Given this list of marker genes EMP1, CEBPB, RBM48, RNF19A, SLC25A30 (solute carrier family 25 member 30), BCL2L11, MALT1, ARF6, NFKBIZ, UTP23, FAM133B, NSMCE1, GUCD1, ZFP1, TNFRSF1B, MAGOHB, IGFBP4, SELP, GBP6, SSH2, SPECC1 (sperm antigen with calponin homology and coiled-coil domains 1), KBTBD8, SCO1, MLLT3, KLHDC2, FAS, FRMD6, FFAR2 (NCBI Gene Id 2867), TIGD2, CEBPD, CASP4, RNF31, RNF149 (NCBI Gene Id 284996), BLTP3B, ABHD17C, MTMR3, ASB2, TIRAP, ZBP1, SYNJ1, IFITM3, STAT3 (NCBI Gene Id 6774), C21orf91, PPP1R16B, MDFIC, SLC41A1, TGM2, ELOVL6, PTPN1, FOSL2, GPR155, LGALS3BP, GPLD1, OSM, PUS7L, NAA16, PPP2CB, ZNF281, RRAS2, RAB27A, TXNRD1, ARAP2, PPAN, SLC2A1, IRGM, SLFN13, NOTCH1, KBTBD11, PCGF5, PRDM1, PDE12, SEMA4D, TCP11L2, GZMB, GNA13, BHLHE40, NFE2L2, SERPINB1, FURIN, SLC39A1, NSD3, ST3GAL4, KSR1, STAT1, SMAD5, TIPARP, RASGRP1, NABP1, BMP2K, TAF5 (TATA-box binding protein associated factor 5), FRMD4B, RTP4, FAM241A, G3BP2, CDKN2D, PPRC1, MAPK6, SLC38A2, SAMSN1, SGK1, PGS1 (phosphatidylglycerophosphate synthase 1), AHR, JAK2, ARMCX6, ARL5A, AOPEP, CRYBG1, IRF9, ZSCAN12, ADORA2B, EGLN3, CSRNP1, PPA1, IL24, PLSCR1, HIF1A, SLC35F5, MXD1, ADAM19, ODC1, DTX3L, TBX21, RRAGD, MAPKAPK2, TNFRSF25, NFIL3, STX11, XAF1, PRNP, ZFPM1, KAT2B, IKZF4, HLX, KRI1, MFSD6, YIPF6, CIRBP, MIDN, EPAS1, TREML2, ABI3, MAP3K8, RAPGEF6, ASF1A, IFI35, LTA, ARMCX3, CHD7, BIRC3, TRIM25, IL6ST, SEC24A, DIS3, IRF7, CGAS, TMEM64, ADPRM, LIF, APEX1, WDR44, AQP9, GJA1, FLOT1 (flotillin 1), CSF1, VPS54, ABHD17B, CD82, SGMS1, GATA1, TWF1, PICALM, RUNX3, XBP1, TNFAIP8, PARP14, PROS1 (NCBI Gene Id 5627), SLC30A4, SLC49A4, PTGER4, UBA3, CHSY1, STAT2, CYTIP, ZFP36, NAF1, SOCS1, SEMA7A, IL12RB2, P2RY14, GNL3, ZNF365, CLDN12, NCBP3, GEM, AJUBA, RAB18, MYD88, CASTOR1, C19orf12, SGO1 (shugoshin 1), here is a description of the gene set: Human Gene Set: GSE22601_IMMATURE_CD4_SINGLE_POSITIVE_VS_CD8_SINGLE_POSITIVE_THYMOCYTE_DN Genes down-regulated in single positive cells: immature CD4 versus CD8 thymocytes. species: Homo sapiens from publication Dik WA, Pike-Overzet K, Weerkamp F, de Ridder D, de Haas EF, Baert MR, van der Spek P, Koster EE, Reinders MJ, van Dongen JJ, Langerak AW, Staal FJ (PMID 15928199) T cells develop from progenitors that migrate from the bone marrow into the thymus. Thymocytes are subdivided roughly as being double negative (DN), double positive (DP), or single positive (SP), based on the expression of the CD4 and CD8 coreceptors. The DN stage is heterogeneous and can be subdivided into four distinct subsets in mice based on the expression of CD44 and CD25. In human, three distinct DN stages can be recognized: a CD34+CD38−CD1a− stage that represents the most immature thymic subset and the consecutive CD34+CD38+CD1a− and CD34+CD38+CD1a+ stages. Human DN thymocytes mature via an immature single positive (ISP CD4+) and a DP stage into CD4+ or CD8+ SP T cells that express functional T cell receptors (TCR) and that exit the thymus. In this study, gene expression was measured in each of these nine stages.